Given this list of marker genes PLD3, LIG4, SAT1, SOAT1, PICALM (phosphatidylinositol binding clathrin assembly protein), RTCB, ITGA2, EIF3L, CDIN1 (NCBI Gene Id 84529), GNAL, SNX8, FRA10AC1, CCN2, HADH, here is a description of the gene set: Werner syndrome (WS) is a premature aging disorder, displaying defects in DNA replication, recombination, repair, and transcription. It has been hypothesized that several WS phenotypes are secondary consequences of aberrant gene expression and that a transcription defect may be crucial to the development of the syndrome. We used cDNA microarrays to characterize the expression of genes and ESTs across a panel of 15 primary human fibroblast cell lines derived from young donors, old donors, and WS patients. Of the analyzed genes, 6.3% displayed significant differences in expression when either WS or old donor cells were compared with young donor cells. This result demonstrates that the WS transcription defect is specific to certain genes. Transcription alterations in WS were strikingly similar to those in normal aging: 91% of annotated genes displayed similar expression changes in WS and in normal aging, 3% were unique to WS, and 6% were unique to normal aging. We propose that a defect in the transcription of the genes as identified in this study could produce many of the complex clinical features of WS. The remarkable similarity between WS and normal aging suggests that WS causes the acceleration of a normal aging mechanism. This finding supports the use of WS as an aging model and implies that the transcription alterations common to WS and normal aging represent general events in the aging process. Human Gene Set: KYNG_WERNER_SYNDROM_UP from publication Kyng KJ, May A, Kølvraa S, Bohr VA (PMID 14527998) studied in species Homo sapiens Genes distinctly up-regulated in primary fibroblast cultures from Werner syndrom patients compared to those from normal young donors.